Given this list of marker genes Atp8a1, Cyb561 (NCBI Gene Id 13056), Syt2, Anxa7, Clu, Ctsl, Dnm1, Syt1, Serpine1, Penk, Slc17a9, Dnajc5, Chga, Dbh, Sri, here is a description of the gene set: Specialized secretory vesicle found in the cells of adrenal glands and various other organs, which is concerned with the synthesis, storage, metabolism, and secretion of epinephrine and norepinephrine. species: Mus musculus Mouse Gene Set: GOCC_CHROMAFFIN_GRANULE